Given this list of marker genes CFLAR, PAM, SLC3A2, GFOD1, UAP1 (NCBI Gene Id 6675), TBC1D8, PGK1, LDLR, SCD, KTN1, GOLGA7, HMGCR, RIN2, OSBPL8, CANX, FDFT1, TIMP2, INSIG1, MARS1, VEGFA, NDRG1, ELL2, AHCY, TNFRSF12A, SQLE, GID4, ATP5F1D, ALDOC, HILPDA, LONP1, SRPK1, ST3GAL1, IRF4, PNP, GART, CYP51A1 (NCBI Gene Id 1595), MYC, BMP6, PRPF40A, GTF2IRD1, HMBS, ADGRE5, FADS1, ACP1, SEPTIN11, GNPDA1 (glucosamine-6-phosphate deaminase 1), XPOT, SLC31A1, AURKA, HK2, GNG10, SERF1A, EIF2S2, CASP3 (NCBI Gene Id 836), TAGLN2, B3GNT2, YARS1, BMI1, UCK2, GRSF1, BCL2, TERT, LDHA, ME2 (NCBI Gene Id 4200), CYCS, MVK, VDAC1, CAV1, CCL3, IDH1, RPP30, SNX9, SLAMF7, PAICS, KRAS, BSPRY, GARS1, CCNC, CTH, HIVEP2, MSMO1, here is a description of the gene set: species: Homo sapiens from publication Shaffer AL, Emre NC, Lamy L, Ngo VN, Wright G, Xiao W, Powell J, Dave S, Yu X, Zhao H, Zeng Y, Chen B, Epstein J, Staudt LM (PMID 18568025) The transcription factor IRF4 (interferon regulatory factor 4) is required during an immune response for lymphocyte activation and the generation of immunoglobulin-secreting plasma cells. Multiple myeloma, a malignancy of plasma cells, has a complex molecular aetiology with several subgroups defined by gene expression profiling and recurrent chromosomal translocations. Moreover, the malignant clone can sustain multiple oncogenic lesions, accumulating genetic damage as the disease progresses. Current therapies for myeloma can extend survival but are not curative. Hence, new therapeutic strategies are needed that target molecular pathways shared by all subtypes of myeloma. Here we show, using a loss-of-function, RNA-interference-based genetic screen, that IRF4 inhibition is toxic to myeloma cell lines, regardless of transforming oncogenic mechanism. Gene expression profiling and genome-wide chromatin immunoprecipitation analysis uncovered an extensive network of IRF4 target genes and identified MYC as a direct target of IRF4 in activated B cells and myeloma. Unexpectedly, IRF4 was itself a direct target of MYC transactivation, generating an autoregulatory circuit in myeloma cells. Although IRF4 is not genetically altered in most myelomas, they are nonetheless addicted to an aberrant IRF4 regulatory network that fuses the gene expression programmes of normal plasma cells and activated B cells. IRF4 target genes induced after activation of primary B lymphocytes by anti-IgM crosslinking. Human Gene Set: SHAFFER_IRF4_TARGETS_IN_ACTIVATED_B_LYMPHOCYTE